Given this list of marker genes MT-TM, RCL1, UTP20, UTP11 (UTP11 small subunit processome component), RRP1, MT-RNR1, MT-TL2, RPL10A, RPS28, RPS26, RPS23, RPS5, PRORP, RPL37A, MT-ND2, RPL41, TBL3, RPL3, RPL36AL, UTP14A, RPL11, WDR18, MT-TV, RPL35A, RPS8, WDR43, RPL8, ELAC2 (NCBI Gene Id 60528), MT-ATP8, RPUSD4, EXOSC5, RPL14, ERI1, RPL23, NOP10, RPL36A, RPS29, RPUSD3, RRP7A, RPS11, DIMT1, RPL21, KRR1, RPL22, RIOK1, EXOSC9, DDX21, NOP14, RPL17, MPHOSPH6, RPL12, UTP14C, RPP38, TRMT112, WDR46, RPS10, 18S rRNA, UTP25, RPL39L, RPS18, RPL5, SNU13, RPS20, RPS19, CSNK1E, FBL, RPSA, RPP40, SENP3, RPL37, 5S rRNA, EXOSC6, BUD23, MT-TK, RPL6, BYSL, RPL31, RPL28, MRM1, MT-ND4, PELP1, NAT10, EXOSC8, C1D, MT-TH (mitochondrially encoded tRNA-His (CAU/C)), DCAF13, MT-TR, MT-TF, RIOK2, MT-TS2, MT-TI, UTP15, DKC1 (dyskerin pseudouridine synthase 1), NOP2, RPL24, NOP56, MT-CO1, RPP30 (ribonuclease P/MRP subunit p30), RPL38, MT-TW (NCBI Gene Id 4578), RPS16, DIS3, RPS27L, MT-ND1 (NCBI Gene Id 4535), RPL10L, NCL, MT-ND5, UTP3, WDR3, RPL10, RPL18, MT-CO2, RPL22L1, UTP4, BMS1, NHP2, NOP58, FTSJ3, RPL29, RPS6, RCC1L, RPL18A, RPS25, MTREX, SNORD3A, RPL35, RPS13, TEX10, NSUN4, EXOSC10 (NCBI Gene Id 8619), RPL32 (ribosomal protein L32), RRP36, RPL9, MT-TT, PWP2, RPS27, DDX49, RPL4, RBM28, EBNA1BP2, RPL23A, UBA52, MT-CO3, RPS14 (NCBI Gene Id 6208), RPP21, UTP18, MRM2, NIP7, MT-ND4L, RPL7, RPLP0, RPS4Y2, RPS15, EXOSC3, RPL26L1, RRP9, RPL13A, TRMT10C, HSD17B10, RNA45S5, IMP3, RIOK3, FASTKD2, RPL36, EXOSC7, NOL12, RPS4X, MTERF4, ISG20L2, RPS3A, RPL27A, WDR36, NGRN, THUMPD1, DHX37, RPS15A, CSNK1D, UTP6, RPL34, RPS4Y1, 28S rRNA, DDX47 (NCBI Gene Id 51202), BOP1, TSR3, MT-ND3, PDCD11, NOB1, RPS17, RPS9, MT-TD, IMP4, LAS1L (NCBI Gene Id 81887), MT-ATP6, RPS2, MPHOSPH10, GNL3, FCF1, RPS12, RPL3L, NOL9, MT-CYB, PNO1, RPL15, RPP25, RPP14, RPL7A, RPLP1, RPL39, PES1, RPL27, RPL30, MT-TL1, NOL11, XRN2, FAU, TFB1M, RPS24, MRM3, EXOSC2, EXOSC4, RPLP2, WDR12, NOL6, RPS7, RPS21, EXOSC1, TRUB2, EMG1, RPS27A (NCBI Gene Id 6233), NOC4L, RPS3, RPL26, HEATR1, MT-TG, RPL19, MT-RNR2, TSR1, MTERF3, GAR1, DDX52, LTV1, RPL13, WDR75, 5.8S rRNA, here is a description of the gene set: Reactome Pathway: rRNA processing Each eukaryotic cytosolic ribosome contains 4 molecules of RNA: 28S rRNA (25S rRNA in yeast), 5.8S rRNA, and 5S rRNA in the 60S subunit and 18S rRNA in the 40S subunit. The 18S rRNA, 5.8S rRNA, and 28S rRNA are produced by endonucleolytic and exonucleolytic processing of a single 47S precursor (pre-rRNA). Transcription of ribosomal RNA genes, processing of pre-rRNA, and assembly of precursor 60S and 40S subunits occur in the nucleolus, with a few late reactions occurring in the cytosol. Within the nucleolus non-transcribed DNA and inactive polymerase complexes are located in the fibrillar center, active DNA polymerase I transcription occurs at the interface between the fibrillar center and the dense fibrillar component, early processing of pre-rRNA occurs in the dense fibrillar component, and late processing of pre-rRNA occurs in the granular component. <br>Processed ribosomal RNA contains many modified nucleotides which are generated by enzymes acting on encoded nucleotides contained in the precursor rRNA. The most numerous modifications are pseudouridine residues and 2'-O-methylribonucleotides. Pseudouridylation is guided by base pairing between the precursor rRNA and a small nucleolar RNA (snoRNA) in a Box C/D snoRNP. Similarly, 2'-O-methylation is guided by base pairing between the precursor rRNA and a snoRNA in a Box H/ACA snoRNP. Other modifications include N(1)-methylpseudouridine, 5-methylcytosine, 7-methylguanosine, 6-dimethyladenosine, and 4-acetylcytidine. Modification of nucleotides occur as the pre-rRNA is being cleaved. However, the order of cleavage and modification steps is not clear so these two processes are presented separately here. Defects in ribosome biogenesis factors can cause disease.<br>Mitochondrial ribosomes are completely distinct from cytoplasmic ribosomes, having different protein subunits and 12S rRNA and 16S rRNA. The mitochondrial rRNAs are encoded in the mitochondrial genome and are produced by processing of a long H strand transcript. Specific residues in the rRNAs are modified by enzymes to yield 5 different types of modified nucleotides: studied in species Homo sapiens part of: Metabolism of RNA